The following is a description of a gene set: The chemical reactions and pathways involving acetyl-CoA, a derivative of coenzyme A in which the sulfhydryl group is acetylated; it is a metabolite derived from several pathways (e.g. glycolysis, fatty acid oxidation, amino-acid catabolism) and is further metabolized by the tricarboxylic acid cycle. It is a key intermediate in lipid and terpenoid biosynthesis. Mouse Gene Set: GOBP_ACETYL_COA_METABOLIC_PROCESS species: Mus musculus, and this is the list of marker genes: Mpc1, Hmgcs2, Acly, Mvk, Pmvk, Pdhb, Acss2, Bckdk, Cs, Pdk1 (pyruvate dehydrogenase kinase, isoenzyme 1), Pdha1, Pipox, Pdhx, Nudt8, Dld, Mlycd, Pdk2, Aadat, Pdk4, Hmgcs1, Csl, Ppcs, Mvd, Acaa2, Acss1, Dip2a, Pgk1, Tdo2, Acot12, Pdk3, Tpk1, Dlat, Vdac1, Kynu, Dlst, Fasn, Nudt7, Pdha2, Acaca, Acacb, Mpc2, Acat1, Aass